The following is a description of a gene set: studied in species Homo sapiens Any process that stops, prevents or reduces the frequency, rate or extent of nuclear-transcribed mRNA catabolic process, nonsense-mediated decay. Human Gene Set: GOBP_NEGATIVE_REGULATION_OF_NUCLEAR_TRANSCRIBED_MRNA_CATABOLIC_PROCESS_NONSENSE_MEDIATED_DECAY, and this is the list of marker genes: NBAS, SECISBP2, PABPC1, A1CF, SYNCRIP, HNRNPAB, UPF3A, APOBEC1, DHX34